Given this list of marker genes Parp1, Parn, Tcp1, Gnl3l, Cct8, Cct4, Cct6a, Cct3, Acd, Cct5, Exosc10, Pinx1, Tinf2, Terc (telomerase RNA component), Nek2, Naf1, Hnrnpc, Mapkapk5, Mapk3, Stn1, Dcp2, Wnt3a, Hnrnpd, Ctc1, Terf1, Mcrs1, Tnks, Xrcc5, Gch1, Rtel1, Pif1, Pot1a, Map2k7, Tent4b, Pot1b (protection of telomeres 1B), Nat10, Map3k4, Tnks2, Slx4, Wrap53, Dkc1, Dhx36, Ercc4, Atm, Src, Ptges3, Hmbox1, Terf2, Pkib, Pml, Mapk1, Nek7, Prkcq, Hnrnpu, Trp53, Cct7, Pnkp, Ten1, Atr, Hnrnpa2b1, Mapk15, Ctnnb1, Cct2, Fbxo4, Aurkb, here is a description of the gene set: Any process that modulates the frequency, rate or extent of telomere maintenance via telomere lengthening. species: Mus musculus Mouse Gene Set: GOBP_REGULATION_OF_TELOMERE_MAINTENANCE_VIA_TELOMERE_LENGTHENING